Given this list of marker genes BAX, BIRC2, ATM, BIRC3, CD40, CASP8, CASP4, GADD45A, here is a description of the gene set: Apoptosis genes up-regulated by TP53 in HCT116 cells (colon cancer) treated with thymoquinone. Human Gene Set: GALI_TP53_TARGETS_APOPTOTIC_UP There are few reports describing the role of p53-dependent gene repression in apoptotic cell death. To identify such apoptosis-associated p53 target genes, we used the pro-oxidant plant-derived drug thymoquinone and compared p53+/+ and p53-/- colon cancer cells HCT116. The p53 wild-type (wt) status correlated with more pronounced DNA damage and higher apoptosis after thymoquinone treatment. A significant up-regulation of the survival gene CHEK1 was observed in p53-/- cells in response to thymoquinone due to the lack of transcriptional repression of p53. In p53-/- cells, transfection with p53-wt vector and CHEK1 small interfering RNA treatment decreased CHEK1 mRNA and protein levels and restored apoptosis to the levels of the p53+/+ cells. p53-/- cells transplanted to nude mice treated with thymoquinone up-regulated CHEK1 expression and did not undergo apoptosis unlike p53+/+ cells. Immunofluorescence analysis revealed that the apoptosis resistance in p53-/- cells after thymoquinone treatment might be conveyed by shuttling of CHEK1 into the nucleus. We confirmed the in vivo existence of this CHEK1/p53 link in human colorectal cancer, showing that tumors lacking p53 had higher levels of CHEK1, which was accompanied by poorer apoptosis. CHEK1 overexpression was correlated with advanced tumor stages (P = 0.03), proximal tumor localization (P = 0.02), and worse prognosis (1.9-fold risk, univariate Cox regression; Kaplan-Meier, P = 0.04). We suggest that the inhibition of the stress response sensor CHEK1 might contribute to the antineoplastic activity of specific DNA-damaging drugs. studied in species Homo sapiens from publication Gali-Muhtasib H, Kuester D, Mawrin C, Bajbouj K, Diestel A, Ocker M, Habold C, Foltzer-Jourdainne C, Schoenfeld P, Peters B, Diab-Assaf M, Pommrich U, Itani W, Lippert H, Roessner A, Schneider-Stock R (PMID 18632613)